Given this list of marker genes TOP1MT, CDCA7, CBFA2T3, NID1, LRRK2, THEM4, MAP4K5, AP1S3, CNFN, ARHGAP31 (Rho GTPase activating protein 31), TOX, CENPN, EGLN2, SNX22, PDE4B, WDR41, FAR2, TSPAN33, PAQR8, FAM98B, PCLAF, KIAA0040, CAMK2G, DUSP4 (dual specificity phosphatase 4), FARP2, PPP1R14A, GNG7, CHST2, MVB12B, CYSTM1, TAP1, BATF3, ADAM19, DUSP18, PDP1, CHN2, IQCE, PARM1, GCSAM, XCR1, CADM1, NET1, BTLA, CLEC2B, MBOAT2, GOLGA8B, NT5C3B, PKIB, MIR181A1HG, FAH, PDLIM7, CLECL1P, ERICH5, ESAM (endothelial cell adhesion molecule), TSPAN2, CD226, C15orf48 (NCBI Gene Id 84562), H2AC13, TMEM102, ANPEP, TIFAB, EPB41, GPR137B, SLC25A12, BCAT2, PMM1, AIM2, ALOX15, OXCT1, CALCRL, FHIP1B, SCARF1 (NCBI Gene Id 8578), NUBPL, TMEM14A, CSRP1, ATP6V0A2 (ATPase H+ transporting V0 subunit a2), KATNA1, ST3GAL2 (ST3 beta-galactoside alpha-2,3-sialyltransferase 2), PAWR, CD38, ENPP1, AGPAT1, LACC1, AHI1, PTPRCAP, CENPBD1P, EGLN3, SEL1L3, CAMK2D, H1-5, APOL3, DGAT2, NCOA7, DLGAP4, TPMT, TSPOAP1-AS1, CYP2E1 (NCBI Gene Id 1571), ENOX1, NMB, BCL6, ARSB, LY75, IRAK2, CLIC2, ADORA3, RHEX, VAV3, CASP9, NOP2, MYCL, ISG20, PDLIM1, SLAMF8, LIMA1, IDH3A, HMOX2, MCOLN2, CXCR3, PLCD1, SLAMF7, CLEC9A, MAP4K1, SULF2, INF2, IGFBP7, HLA-DOB, IFT57, RAB3IP, RFPL4AL1, VAC14, SLC9A7, ROBO1, AP4B1, CLEC1A, WDFY4, MAP3K4, UPK3A (uroplakin 3A), PTK2, GPT2, QRSL1, HMGN4, PTPN22, TMEM38B, S100B, TRIP6, H2AC17, TMEM156, LMNB1, FBXO27, RAB30, LDLRAD4, FNIP2, KIF16B, FMNL2, ZNF366, TLR10, P2RY14, SERPINB9, ACSL5, ATP2A3, TMEM191C, TOMM34, ERAP2, SLC38A1, SERPINF2, FUT8, GRAMD2B, CYFIP2, HLA-DQB2 (NCBI Gene Id 3120), TP53RK, PDE6D, BEND5, RFPL4A, RMI1, RHOF, PPY, CD40, B4GALT4, CYYR1, SPINT1, NCKAP5, ECHDC2, SVIP, LONRF1, QPCT (glutaminyl-peptide cyclotransferase), TACSTD2, LYRM4, STK17A, ISYNA1, DENND1B, TSPAN13, TRPV2, H3C10, C10orf105, DST, ASB2, DPP4, RUBCNL, SNRNP25, LMNA, SEPTIN11, APOL2, LRRCC1, SMASR, SLC25A29, MYO9A, DBN1 (NCBI Gene Id 1627), NAV1, KLHL22, SPATS2 (spermatogenesis associated serine rich 2), MCM7, DCTPP1, CHRFAM7A, SLC25A20, PDE4DIP, BTN2A2, PELO, IDO1, FKBP1B, HSH2D, P2RY10, AP3M2, CKB (creatine kinase B), HLA-F (major histocompatibility complex, class I, F), SIGLEC10, TMEM191B, CRYBG3, REPS1, FLNB, PIGZ, HACD2, AP1G2, PPM1J (protein phosphatase, Mg2+/Mn2+ dependent 1J), CLCN4, CCDC122, STX3, CSKMT, ACOT7, GPR160, TSPAN15, SP140, NUP210, POLA2, FAM135A, ZBED3, OAT, CRIP3, CCSER1, PLEKHA5 (pleckstrin homology domain containing A5), TMEM97, MAP2K6, NAA40, PON2, C1orf54, GRAP2, DIPK2A, REEP3, CLNK, REC8, FRY, ABHD6, RAB29, TRERF1 (NCBI Gene Id 9565), ST14, USP1, RAB7B, RAB11FIP4, HSPBP1, COMTD1, PTGER2, PTTG1, CCDC146, NBPF12, NAE1, PLPP1, ZDHHC18, GLTP (glycolipid transfer protein), FARS2, GFOD1, PIK3CB, DOP1A, INPP5F, TSTD1, NIBAN1, CCDC126, RFTN1, RCN2, THBD, TK1, RUSC1, OXSR1, ECE1, SLC46A3, B3GNT7, HTR3A, DAPK2, MTERF2, SLC24A4, ZEB1, SLC66A1, CTNNAL1, SH3RF2, ACSS2, CCND1, PLEKHM3, PNMA1, MAP3K20, MACROH2A2, NCALD, ITGB7, ZNF296, TAP2, MIR4435-2HG, HPS5, CYP2S1, PRELID2, RBBP8, KIAA1958, ACAP1, C1orf21, P3H2, RGCC, STRADB, NAPSA (napsin A aspartic peptidase), FLT3, H2AC14, NEGR1, DNASE1L3, here is a description of the gene set: from publication He P, Lim K, Sun D, Pett JP, Jeng Q, Polanski K, Dong Z, Bolt L, Richardson L, Mamanova L, Dabrowska M, Wilbrey-Clark A, Madissoon E, Tuong ZK, Dann E, Suo C, Goh I, Yoshida M, Nikolić MZ, Janes SM, He X, Barker RA, Teichmann SA, Marioni JC, Meyer KB, Rawlins EL (PMID 36493756) DC1 Human Gene Set: HE_LIM_SUN_FETAL_LUNG_C2_DC1_CELL studied in species Homo sapiens